The following is a description of a gene set: Human Gene Set: GOCC_NEURON_PROJECTION_MEMBRANE species: Homo sapiens The portion of the plasma membrane surrounding a neuron projection., and this is the list of marker genes: MPP2, LAMP5, CLCN2, KCNB1 (NCBI Gene Id 3745), SLC9A5, GABRA3, SHISA6, STX4, GABRA1, TACR3, HCN1, ATP2B2, ATP6AP2, SHISA8, PKHD1L1, ADGRV1, ROBO2, SHISA9, AKAP5, HCN2, GPER1, DAGLA, MYO1D, ADORA2A, GABRA6, ATF4, ITGA8, MAPT, TRPV1, GABRA2, GRIA1, GABRA4, MYO1C, GABRG1, OPRD1, SPTBN1, GABRA5, HPCA, PPP1R9B, GABBR1, SLC12A5, DDN (dendrin), KCNC2, VEZT, GABRE, SLC1A2, RIPOR2 (NCBI Gene Id 9750), KCNC3, KCNC1, UNC5A, THY1, APP, GABRG3, GABRG2, SGCE, USH2A, CNTNAP2 (NCBI Gene Id 26047), EPB41L3, INSR, CLRN2, CACNG8, SHISA7, ANK1, KCNC4 (NCBI Gene Id 3749), ADORA1